Given this list of marker genes PPP2R2D, KHDRBS2, BLCAP, PDE3A, CTDSPL2, SYT15, RNF139, BMPR1B, SSH1, PCDHA12, LAMTOR3, SLF2, FAM184A, RALA, PCDHA6, PCDHA13, USP37, RORA, RNF19B, PLCXD1, TENT4B, PCDHA7 (NCBI Gene Id 56141), DUSP10, METTL9, CADPS2 (calcium dependent secretion activator 2), CCNI2, AP5M1 (adaptor related protein complex 5 subunit mu 1), ZFHX4, PTDSS1 (phosphatidylserine synthase 1), PCDHB10, EXOG, RADX, TNRC6B, TCEA1, ADAMTS9, SLC6A19, SRSF4, CAPZB, ZNF667, SLC26A2, MCAM, PDE5A (NCBI Gene Id 8654), MESD, PITPNB, ARL4A, FXR2, AK4, DLGAP4, EPPK1, KLHL2, CDK1, PTBP2, ZBTB18, KDM7A, PAIP2B, PPP1R3B, ADGRF5, EIF4G3, PCDHA10, PHF21A, PAM, NKD1, NAV3, POC1B, PCDHAC2, PCDHA4, ANK3, PERP, TMEM245, SMNDC1, CHL1, PTPRJ, BCL7A, SHB, KRIT1, WDR5B, SLC44A1, EIF4B, ZNF304, PCDHA3, ARHGAP21, OTULINL, VOPP1, GRB2, GNA12, RNF38 (NCBI Gene Id 64796), C9orf72, EPHA4, CEP85L, EIF4G1, PCDHA1, CSNK1G3, WAPL, PCDHA2 (NCBI Gene Id 56146), FSTL3, SOCS6, RLN1, NRP2, PCDHA5, PCDHA9, DAAM1, GABRB2, SSBP2, PCDHA11, RAI1 (retinoic acid induced 1), INO80D, ATAD2, ASXL1, ZNF281, NRBF2, RTL5, FPGT, KLF6, HIPK1 (NCBI Gene Id 23323), PCDHAC1, here is a description of the gene set: Human Gene Set: MIR329_3P from publication Chen Y, Wang X (PMID 31504780) species: Homo sapiens Genes predicted to be targets of miRBase v22 microRNA hsa-miR-329-3p in miRDB v6.0 with MirTarget v4 prediction scores > 80 (high confidence targets).